The following is a description of a gene set: studied in species Homo sapiens Human Gene Set: HP_OBESITY Obesity Accumulation of substantial excess body fat., and this is the list of marker genes: STX16, IFT27, HLA-DRB1, POMC, WNT4, AIP, SMARCB1, PRKAR1B, GP1BB, FXR1, SCLT1, USP48, ADCY3, DEAF1 (NCBI Gene Id 105376508), GATA4, TMEM270, BRAF, METTL27, GNAI1, TRAPPC9, MC4R, SETBP1 (SET binding protein 1), CFAP418, LEP, MAGEL2, CEP19, KIDINS220, IFT74, TBC1D2B, SNRPN, COPB1, TUB, SDC3, FKBP6, TTC8, XRCC4, MLXIPL, NIPBL, MIA3, SECISBP2, HNF4A, SLC10A7, HNF1A, EXOC6B, KLF11, TBX1, OFD1, PHIP, CEL, CELA2A, LARS2, AP1S3, SHOX, APPL1, RFC2, OTX2, PDX1, ABCB4, MAPK8IP3, SPG11, CASZ1, PRMT7, SCAF4, ANOS1, INS, ERMARD, WAC, IER3IP1, SUPT16H, SCAPER, APOE, SYNE1, SIM1, ZBTB20, LMNA, GTF2IRD1, SMO, MEG3, GCK, KDM6A, PNKP, PTEN, PROK2, PIK3CA, IFT172, BLK, VPS37D, SPEN, MEGF8, RAP1B, STEEP1, CTSH, CEP164, PDE4D, HLA-DQB1, BBS5, NCF1, HESX1, AKT2, NR3C1, AKT1, FGD1, ALMS1, CARTPT, TACR3 (tachykinin receptor 3), CDH23, TAF6, FOXP1, GABRA3, UCP3 (NCBI Gene Id 7352), MYT1L, PDGFB, EIF4H (eukaryotic translation initiation factor 4H), DYRK1B, RAI1, RTL1, POU3F4, PIGT, PSMD12, CANT1, PCSK1, CHD7, DMPK, SKI, FGFR3, SOX3, CNNM2, NHLH2, LUZP1, PGM2L1, SLC7A7, SDCCAG8, MECP2, PRORP, FGFR1, BUD23 (NCBI Gene Id 84118), NDN, ADRB3, WDR11, PWRN1, USP8, IGF1R, GABRD, LIPE, PPARG, POGZ, COL10A1, KCNJ11, PROKR2 (NCBI Gene Id 3733), RERE, SMC3, NR0B2, DLK1, TP53, HS6ST1, CCDC141, FLRT3, GNAS-AS1, ATP6AP2, FGF8, INPP5E, COMT, IL36RN, SMC1A, CUL4B, ALB, ENPP1 (ectonucleotide pyrophosphatase/phosphodiesterase 1), KCNAB2, TRAF3IP1, LAS1L, BDNF, RBMX, STX1A, NIN, MAN1B1, ARMC5 (NCBI Gene Id 79798), GJA8, RREB1, IL17RD, CREBBP, TAF1, TCF20, PDE11A, PCNT, SH2B1, BBS1, TOGARAM1, GHRL, SRY, GNAS, SPRY4, SETD1A, GTF2IRD2, COA3, TRAF7, SOX10, NDNF, TRIM32, SNORD115-1, BBS10, ACBD6, BBS7 (NCBI Gene Id 55212), ACADVL, BAP1, MKRN3, ATP10A, TMEM43, HSD11B1, ABHD5, SUFU, FLII, PAX4, TRIP12, MMP23B, PNPLA2, ZPR1, AGRP, MKKS, CNTNAP2, SEC24C, CYP19A1, PHF6, RNPC3, SEMA3A, KCNJ18, HDAC8, PDPN, BRD4, ZNF711 (NCBI Gene Id 7552), EMD, MKS1, SETD2, ABCC8, ELN, SMARCE1, LEPR, PDSS1, NF2, RAB23, WT1, THOC2, TFE3, PNPLA6, TMLHE, BBS12, HIRA (histone cell cycle regulator), DDX6, LIMK1, SMAD4, CACNA1S, HACE1, UBE3A, SRRM2, CEP290, PRKCZ, SLC25A4, IQSEC2, CCDC28B, UBE4B, UBE3C, P2RY11, FBXO11, EHMT1, FHL1, IGF1, FEZF1, SPTBN1, SIN3A, FMR1, CPE, EIF2S3, GHR, MEF2A, ARVCF, FGF17, DPYD, SYNE2, SNORD116-1, CTNNB1, LZTFL1 (leucine zipper transcription factor like 1), HECTD4, TERT, PRKAR1A, TNFSF4, CFAP410, HCRT, UFD1, ARNT2, DNAJC30, HDAC4, ZNF365, PHF21A, CLIP2, JMJD1C, SATB1, DNMT3A, MOG, DUSP6, NKAP, DDB1, NEUROD1, SH3KBP1, GJA5, KDM1A, TBX3, CYP7A1, BLM, IGFALS, GTF2I, ARL6, HSPG2, TMEM67, HERC2, XYLT1, NTRK2, NPHP1, PKDCC, SOX2, BBIP1, OCA2, BBS9 (NCBI Gene Id 27241), PRDM16, ARL13B, MTFMT, ATRX, DCC, RPS6KA3, PHLDB1, H6PD, TBL2, BBS4, AFF4, NPAP1, VPS13B, RAD21, MCM3AP, BPTF, EP300, ADNP, PWAR1, PAX6 (NCBI Gene Id 5080), WDPCP, DYNC2I2, BBS2, CHD8, HEATR3, P4HTM, BAZ1B, KMT2D